The following is a description of a gene set: from publication Chen Y, Wang X (PMID 31504780) Genes predicted to be targets of miRBase v22 microRNA mmu_miR_7647_3p in miRDB v6.0 with MirTarget v4 prediction scores > 80 (high confidence targets). studied in species Mus musculus Mouse Gene Set: MIR_7647_3P, and this is the list of marker genes: Ddx21, Rimkla, Gimap6, Zfp36l2, Hspa5, Dnajb11 (DnaJ heat shock protein family (Hsp40) member B11), Ppp2r2a, Kcnh4, Slc25a16, Ctnnd1, Dennd2d, Trim46, Map9, Aptx, Tradd, Chmp6, Rgp1, Cpne9, Gria4 (glutamate receptor, ionotropic, AMPA4 (alpha 4)), Ubash3b, Adnp, Eif6, Pou3f2, Txlng, Rad52, Arl15, Fcrla (Fc receptor-like A), Rnf144b, Bmp4, Kl, Amd1, Sypl2, Spats2, Faxc, Ube2g1, Pate6, Rhobtb2, Thnsl1, Zfp277, Kcna1, Tarbp1, Amd2, Zfc3h1, Pmp22, Hmg20b, Ppfia4, Rgl1, Tmem253, Qki, Atxn7 (ataxin 7), Fgf7, Sar1a, Kank4, Ppwd1, Kdm7a